The following is a description of a gene set: studied in species Homo sapiens Human Gene Set: GSE22611_UNSTIM_VS_2H_MDP_STIM_MUTANT_NOD2_TRANSDUCED_HEK293T_CELL_UP Genes up-regulated in HEK293 cells expressing mutant NOD2: untreated versus muramyl dipeptide for 2h. NOD2 is an intracellular receptor for the bacterial cell wall component muramyl dipeptide (MDP) and variants of NOD2 are associated with chronic inflammatory diseases of barrier organs e.g. Crohn disease, asthma and atopic eczema. It is known that activation of NOD2 induces a variety of inflammatory and antibacterial factors. The exact transcriptomal signatures that define the cellular programs downstream of NOD2 activation and the influence of the Crohn-associated variant L1007fsinsC are yet to be defined. To describe the MDP-induced activation program, we analyzed the transcriptomal reactions of isogenic HEK293 cells expressing NOD2wt or NOD2L1007fsinsC to stimulation with MDP. Importantly, a clear loss-of-function could be observed in the cells carrying the Crohn-associated variant L1007fsinsC, while the NOD2wt cells showed differential regulation of growth factors, chemokines and several antagonists of NF-κB, e.g. TNFAIP3 (A20) and IER3. from publication Billmann-Born S, Till A, Arlt A, Lipinski S, Sina C, Latiano A, Annese V, Häsler R, Kerick M, Manke T, Seegert D, Hanidu A, Schäfer H, van Heel D, Li J, Schreiber S, Rosenstiel P (PMID 21335489), and this is the list of marker genes: CRYGD (crystallin gamma D), RABAC1, GLTP, SH3BGRL, HTR2B, HIKESHI, PRDM11, DUSP22, INSIG1 (NCBI Gene Id 3638), NPY5R, GCLM, TCEA2, RAB11FIP1, JAG1, LILRB2 (leukocyte immunoglobulin like receptor B2), ZNF239, ANKRA2, WTAP, TESPA1, IL22, SPARCL1, P2RX3, PPP1R11, RPL23AP32 (NCBI Gene Id 56969), IL36G, PRKAB2, ELOVL5, NIPSNAP2, ZNF205, ITPR1 (inositol 1,4,5-trisphosphate receptor type 1), SARAF, UFC1, TSKS, CFB, TMEM260, CRTC3, PLD1, CLCA2, ALAS1, SLC16A1, GLRX, MERTK, ELMO1, GDPD3, BTBD1, KLF7, ARHGEF1, GSC2, PARP6, NPRL2, FRYL, LPXN, SUN2, PROZ, DGKD, TSHB, ADCY7, CARS1, RCN2, TRAPPC13, IFRD1, ARL5A, UBAC1 (NCBI Gene Id 51408), C11orf58, MAPK11, MCUB, ERLIN1 (ER lipid raft associated 1), HGF, NEMF, RGS14 (regulator of G protein signaling 14), SSH1, ALDH9A1, TXN2, MGLL, RALBP1, ARPC4, ACTN2, NR5A2, CDC42BPA (NCBI Gene Id 9876), TBP, OSGEP, DDB1, ELAC2, R3HCC1, ACTN4, TUT4, CSTF1, CBX7, TRMT5 (tRNA methyltransferase 5), SCLY, GPR12, DRAM1, FBXW2, RNF139 (ring finger protein 139), CD59, TXN, FICD, P2RX4, RNF7, FAM131A, MYCNOS, NADSYN1, CZIB, SIVA1, MAP3K3, KCTD20, TAS2R14, SDHAP1, ACTL8, SNX17, IFT52, ABLIM1, C1orf54, CSF2, TOB1, ABCB1, VAMP7, HIF1AN, BCORL1, PTPN11 (NCBI Gene Id 84990), ZNF263, KCNJ9, RPAP3, NEIL1, DPYSL2, SPCS1, CACNB3, AATF, APOBEC3A, SLBP, RBFOX1 (NCBI Gene Id 54715), TSPYL4, UBE2M, CHD4, MAST2, DCK, RNF128, B3GNT2, TOR3A, RALGPS1, PRKCSH, PRPF3, TBCB, BEX3, CHUK, BPTF, MSRB2, ZNF562, SH3BP2, VPS16, CIB1 (NCBI Gene Id 10519), LPGAT1, TOPBP1, APOBEC2, NCK2, SDHA, TMEM134, RFXAP, FBXL12, FGF18, ANXA5, PSMD9, PEX11B, SNN, DEDD, MAP3K8, H3C6, SLAMF7, TXNL4B, CSF1R, CXCL2, TGFBI, GABPB1, PALLD, TUBGCP4, INTS11, OR7E36P, SLCO3A1, MAP3K5, PLPP3, ACVR2B, AOAH, CCNG1, AHSG, GZMH, ERLIN2, BBS10, WRAP73, BORA, SLC35F2, INPP5D, ANKS1A (ankyrin repeat and sterile alpha motif domain containing 1A), ARHGEF17, ZNF133, IL12B, NODAL, TBXT, PBX2